The following is a description of a gene set: Mouse Gene Set: GOBP_PYRIMIDINE_NUCLEOSIDE_CATABOLIC_PROCESS The chemical reactions and pathways resulting in the breakdown of one of a family of organic molecules consisting of a pyrimidine base covalently bonded to a sugar ribose (a ribonucleoside) or deoxyribose (a deoxyribonucleoside). species: Mus musculus, and this is the list of marker genes: Cda, Upb1, Dpyd, Pycr3, Aicda, Cdadc1, Upp2, Dctd, Upp1